Given this list of marker genes CYP1A2, CYP2C8, CYP1A1, CYP3A43, CYP1B1, CYP3A4, CYP3A5, CYP3A7, here is a description of the gene set: Catalysis of the reaction: estrogen + reduced + O2 = 16-alpha-hydroxyestrogen + oxidized + H2O. Human Gene Set: GOMF_ESTROGEN_16_ALPHA_HYDROXYLASE_ACTIVITY species: Homo sapiens